Given this list of marker genes IL2RB, JAK1, STAT5A, IL2, STAT5B, JAK3, IL2RG, here is a description of the gene set: HTLV-1 p12 to Jak-STAT signaling pathway. Pathway ID: N00491. Pathway type: Pathogen. Pathway class: nt06518 JAK-STAT signaling. Human Gene Set: KEGG_MEDICUS_PATHOGEN_HTLV_1_P12_TO_JAK_STAT_SIGNALING_PATHWAY species: Homo sapiens Pathway Definition from KEGG: P12 -> IL2RB/G -> JAK1/3 -> STAT5 => IL2